Given this list of marker genes Ddx11, Fosl2, Col6a1, BC004004, Timeless, here is a description of the gene set: Any process that results in a change in state or activity of a cell or an organism (in terms of movement, secretion, enzyme production, gene expression, etc.) as a result of a bleomycin stimulus. studied in species Mus musculus Mouse Gene Set: GOBP_RESPONSE_TO_BLEOMYCIN